Given this list of marker genes IKBKB, AHSA2P, LRRC10B, ANKRD36, RFPL2, DMKN, MTSS2, LCOR, STAT2, LMOD2 (leiomodin 2), PKD1P1, ADAM11, TMEM132E, TEX11, N4BP2L2-IT2, CCDC144CP, SIMC1P1, LINC00938, MC1R, ACAD10, CSAD, LINC01095, TPSD1, KCNQ2, ATG12, MIOS, ST3GAL4, TTC32, ZNF83, PIN1P1, GRK1 (NCBI Gene Id 6011), MKX, RBM6, CLK4, KCNQ4, PCED1A, CDK5RAP3, KRT36, IRS1, CHST6, ST3GAL2, IFIT3, FAM133B, DYNC1LI2, KMT2C, ZNF177, ZNF655, EZH2, SUPT7L, MYL6B, SNX27, PRLH, CCDC142, CNOT4, NR2C1, A4GALT (NCBI Gene Id 53947), SLC25A5-AS1, ZFYVE26, SIX4, FKBP14, RNF166, SPMIP8, TSPEAR, CIMAP1B, MEG3, CCDC27, ZNF473CR, FAM110D, RBM5, GPR45, ABCB10, TSPAN16, MARK3, EBF4, SCNN1A, KDM5D, B3GAT2, SNX29P2, ZIC1, PDXDC1, ADIRF, CDH15, SPEF1, PSMA3-AS1, BTN2A1, CEP78, PATL2, LINC-PINT, AHCTF1, IFIT2 (NCBI Gene Id 8375), LINC02532, SREK1, EMC3-AS1, SPTBN2, BHLHE22, MAT2A, CRYGS, MALAT1, TOPBP1, SPIC, HOXA11-AS, METTL3, ZNF471, HERC2P3, SMAD5-AS1, KLRG2, VSTM4, LINC02112, MRRF, FNBP4, ZFYVE16, TRARG1, MTIF2, MEX3B, ZNF84, CAPS, FUZ, ABCD4, REG1A, UBR2, NR5A1, DUOXA2, GP1BB, NRXN2, CSPG4BP, FBXL19, COCH, PKDCC, CCT6B, NEAT1, ZNF333 (NCBI Gene Id 84449), IGFBP5, CHST8, GXYLT1, BMP4, PRSS40A, NPHP3, ELFN1, TNR, DGAT2-DT, FBXL17, GK, WNK4, ST8SIA1, POLR1B (NCBI Gene Id 88998), LRRCC1, MPIG6B, ASH1L, PCDHGA8, SUN3, LIF, RAD52, OLFM4, CCDC134, SLC38A5, MICAL1, FABP2, SS18L1, HNRNPH1, CCNL1, ARG1, STATH, SCML1, BRSK1, MST1R, TRA2A (transformer 2 alpha homolog), STX3, SLC24A5, ABCC6, CEND1, MAN2A2, GAREM1, PITPNA-AS1, EPS8L1, PRKRIP1, CLCA1, BVES-AS1, DENND4A, PPWD1, TUT4, NEB, AFG3L1P, CRYGD, here is a description of the gene set: The dendritic cell (DC) is a master regulator of immune responses. Pathogenic viruses subvert normal immune function in DCs through the expression of immune antagonists. Understanding how these antagonists interact with the host immune system requires knowledge of the underlying genetic regulatory network that operates during an uninhibited antiviral response. In order to isolate and identify this network, we studied DCs infected with Newcastle Disease Virus (NDV), which is able to stimulate innate immunity and DC maturation through activation of RIG-I signaling, but lacks the ability to evade the human interferon response. To analyze this experimental model, we developed a new approach integrating genome-wide expression kinetics and time-dependent promoter analysis. We found that the genetic program underlying the antiviral cell state transition during the first 18-hours post-infection could be explained by a single regulatory network. Gene expression changes were driven by a step-wise multi-factor cascading control mechanism, where the specific transcription factors controlling expression changed over time. Within this network, most individual genes are regulated by multiple factors, indicating robustness against virus-encoded immune evasion genes. In addition to effectively recapitulating current biological knowledge, we predicted, and validated experimentally, antiviral roles for several novel transcription factors. More generally, our results show how a genetic program can be temporally controlled through a single regulatory network to achieve the large-scale genetic reprogramming characteristic of cell state transitions. Genes down-regulated in comparison of control conventional dendritic cells (cDC) at 2 h versus cDCs infected with Newcastle disease virus (NDV) at 2 h. studied in species Homo sapiens from publication Zaslavsky E, Hershberg U, Seto J, Pham AM, Marquez S, Duke JL, Wetmur JG, Tenoever BR, Sealfon SC, Kleinstein SH (PMID 20164420) Human Gene Set: GSE18791_UNSTIM_VS_NEWCATSLE_VIRUS_DC_2H_DN